Given this list of marker genes Cacnb2, Gm13268, Gm13311, Arl5b, Gm13365, Gm13368 (predicted gene 13368), Gm13313, 2900092N22Rik, Gm10848 (predicted gene 10848), Tmem236, Malrd1, Plxdc2, Mir511, Slc39a12, Gm13367, Gm13269, Gm37416, Gm13366, Gm13266, Mrc1, Gm6587, Gm13316, Nsun6, Gm13315 (NCBI Gene Id 674815), here is a description of the gene set: studied in species Mus musculus Mouse Gene Set: chr2A2